Given this list of marker genes IGFBP3, IGF2, FN1, PODXL, GJA5, HEY1, RHOB, PCSK5, ICAM2, KCTD12, SEMA3G (NCBI Gene Id 56920), THSD7A (NCBI Gene Id 23249), S100A4, CXCL12, PPA1, GJA4, ADAMTS1, HES4, EDN1, SAT1, DEPP1, ALPL, DLL4, STMN1, ATP13A3, FBLN5, SULF1, ADAMTS6, VEGFC, SERPINE2, ARL15, MECOM, STC1, FBLN2, NHERF2, EMP3, NUDT4, SOX17, JAG1, CLDN5, CXCL2, SRGN, PLPP1 (phospholipid phosphatase 1), ENPP2 (ectonucleotide pyrophosphatase/phosphodiesterase 2), PLLP, FAM107A, PPP1R14A, EFNB2, JAG2, LTBP4, here is a description of the gene set: from publication Gavish A, Tyler M, Greenwald AC, Hoefflin R, Simkin D, Tschernichovsky R, Galili Darnell N, Somech E, Barbolin C, Antman T, Kovarsky D, Barrett T, Gonzalez Castro LN, Halder D, Chanoch-Myers R, Laffy J, Mints M, Wider A, Tal R, Spitzer A, Hara T, Raitses-Gurevich M, Stossel C, Golan T, Tirosh A, Suvà ML, Puram SV, Tirosh I (PMID 37258682) Human Gene Set: GAVISH_3CA_METAPROGRAM_ENDOTHELIAL_NOTCH_SIGNALING Genes upregulated in subsets of cells of a given type within various tumors species: Homo sapiens In this study, an extensive analysis was conducted to define meta-programs (MPs) capturing intra-tumor heterogeneity across a spectrum of tumor types. The approach utilized non-negative matrix factorization (NMF) to analyze each cell type separately within individual tumor samples. This involved the analysis of malignant cells, macrophages, fibroblasts, endothelial cells, epithelial cells, T-cells, and B-cells. NMF was executed with varying parameter values (K=4, 5, 6, 7, 8, 9), thereby generating 39 programs for each cell type per sample. Each NMF program was summarized by the top genes based on NMF coefficients.\nRobust MPs were then delineated for each cell type using a set of stringent criteria, including recurrence within the same tumor, similarity to programs in other tumors, and non-redundancy within a tumor. Subsequently, these robust NMF programs were clustered (per cell type) based on Jaccard similarity, leading to the identification of MPs associated with each cell type.\nTo enhance the quality of the MPs, a refinement steps were undertaken, involving the removal of MPs suspected of reflecting low-quality data (with an overrepresentation of ribosomal proteins or mitochondrial-encoded genes), single-study inclusion, or similarity to miss-annotated cell types.